Given this list of marker genes Igkc, Serpina1d, H2-Aa (NCBI Gene Id 406213), Adipoq, Alb, Serpina1c, Jchain, Mpeg1, H2-Q10, Acta1, Cxcl9, Cdkn1c, H2-K1, H2-T22, Igkv1-135, Cyp2e1, here is a description of the gene set: studied in species Mus musculus Mouse Gene Set: WUNDER_INFLAMMATORY_RESPONSE_AND_CHOLESTEROL_DN Genes down-regulated in gastric mucosal tissue of mice on 2% cholesterol diet and infected with H. pylori vs those infected with H. pylori while on 0% cholesterol diet. from publication Wunder C, Churin Y, Winau F, Warnecke D, Vieth M, Lindner B, Zähringer U, Mollenkopf HJ, Heinz E, Meyer TF (PMID 16951684) Helicobacter pylori infection causes gastric pathology such as ulcer and carcinoma. Because H. pylori is auxotrophic for cholesterol, we have explored the assimilation of cholesterol by H. pylori in infection. Here we show that H. pylori follows a cholesterol gradient and extracts the lipid from plasma membranes of epithelial cells for subsequent glucosylation. Excessive cholesterol promotes phagocytosis of H. pylori by antigen-presenting cells, such as macrophages and dendritic cells, and enhances antigen-specific T cell responses. A cholesterol-rich diet during bacterial challenge leads to T cell-dependent reduction of the H. pylori burden in the stomach. Intrinsic alpha-glucosylation of cholesterol abrogates phagocytosis of H. pylori and subsequent T cell activation. We identify the gene hp0421 as encoding the enzyme cholesterol-alpha-glucosyltransferase responsible for cholesterol glucosylation. Generation of knockout mutants lacking hp0421 corroborates the importance of cholesteryl glucosides for escaping phagocytosis, T cell activation and bacterial clearance in vivo. Thus, we propose a mechanism regulating the host-pathogen interaction whereby glucosylation of a lipid tips the scales towards immune evasion or response.